Given this list of marker genes SLC6A19, UPF1, PARP14, UBA52, MACROH2A1, TAB1, APOA1, MACROD1, PALS1, PAIP1, CMTR1, GDAP2, TOMM70, UBB, MACROD2, MRM2, UPF2, NLRP12, UBC, MACROH2A2, AQR, ACE2, ISG15, NRP1, IGHMBP2, PARP9, here is a description of the gene set: studied in species Homo sapiens COVID-19 structural coverage map Human Gene Set: WP_COVID19_STRUCTURAL_COVERAGE_MAP